The following is a description of a gene set: Mouse Gene Set: ZFP953_TARGET_GENES from publication Yevshin I, Sharipov R, Kolmykov S, Kondrakhin Y, Kolpakov F (PMID 30445619) species: Mus musculus Genes containing one or more binding sites for (Zfp953) in their promoter regions (TSS -1000,+100 bp) as identified by GTRD version 20.06 ChIP-seq harmonization., and this is the list of marker genes: Gm26795, Pnliprp1, Altre, Ahcyl1, Gm7094, Gm8883, Cylc2, Gm24665, Ube2h, Adcy10, Gm15066, Glrx5, Gm22935, Arl2bp, Vdac1, Or4c35, Gm6366, Mycbp2, Faddos (NCBI Gene Id 100038412), Eva1c, Pzp, Gm9506, AA986860, Dhx9, Rian, Gzmm, Bola3, Scpep1, Map3k5 (NCBI Gene Id 320994), BC048507, Gigyf2, Capn11, Ndufa12-ps, Gm42799, Ppp2r5c, Oscp1, Pdk1, Becn2, Mcts1, Mdk, Gm13916, Gm12340, Glra2, Snph, Acbd6, Zfp212, Gm5466, Frmpd4, Exosc2, 2210417A02Rik, Urgcp, 2900079G21Rik, Fam76a, Zp1, Fam219aos, Mphosph9, Slc22a7, Zan, Scarb1, Krtap22-2, Gm13094, Zmiz2, Rpl10-ps2, Parn, Slc7a2, H2-M2, Mir21c, Creb3l3, Kcnip4, Arfgef1, Cracr2a (calcium release activated channel regulator 2A), Ift122 (intraflagellar transport 122), Mlxip, Supt7l, Kdm3b, 1700023H06Rik, Plaa, Aldh2, Spata1, Rfx4, Zfp512b, Gm15782, Gm5255 (predicted gene 5255), Ttc39c, Ell3, Gm8213, Myo5b, Cnppd1, Tmem131, Ncmap, Gm12980, Senp3, Asah1, Mettl13, Mir103-2 (microRNA 103-2), Gm11872, Pou2f2, Mysm1, Epha10, Ccdc28a, Nicn1, Cenpe, Zeb1os1, Tbx15, Gm12803, P2rx7, Ltbp3, Gm10059, Prrc2a, Maf, Cacna2d4, Dot1l, Stag1, Speg, Chchd10, Gm11197, Luc7l3, Prdm10, Afdn, Gpkow, Stat3, Gfm1, Mcf2l, Nudt5, 4930556N13Rik, Ms4a4c, Gm14016, Manba, Mir1947, Kctd13, Usp4 (NCBI Gene Id 22258), Ncor1, Or2t43, Zbtb11, Rps13-ps6, Rtl5, Alg13, Gm25609, Cav1, Cyp4a28-ps, Pcsk6, Lgals4, Rcbtb1, Gm26343, 4930505A04Rik, Gm19705, Nt5el (5' nucleotidase, ecto-like), Rab34, Ext1, Aatf, Nrip1, Dsc1, Emx2, Gm14752, Srsf1, Rsph14, AU016765, Csn1s2b, Smagp, Rab11a, Tal1, Nr5a2, Mir6367, Rsl1d1, Unc13b, Zfand2a, A230083N12Rik, Adcy7, Gm26081, Gm11691, Tgif1, Pcdhb18, Gm13842, Rell1, Mir450-2, Dab2 (NCBI Gene Id 70555), Lrrc23, Cit, Cenpi, Kat2b, Slc11a2, Scin, Cp, Ptges3, Gm34248, C9, Nhsl2, 5830432E09Rik, Pcdh19, Lpin2, Mkrn2os, Klhl18, Or6n1, Aars1, Slc1a1 (NCBI Gene Id 319379), Phb1, Bdh2, Ipo13, Myom3 (NCBI Gene Id 433768), Hspa8, Ubr1, Rhbdd2 (rhomboid domain containing 2), Mtfr1, Shf, Mindy3, Slc34a2, Mzf1, Adck2, Mamstr, Baz1b, Abo, Prss40, Prpf38b, Gm26725, Slc6a20b, H2-M5, 5830487J09Rik (RIKEN cDNA 5830487J09 gene), Tifab, Gm6096, Rnaseh2a, Got1l1, Fbxo42, Atp5f1b, Cfp, Garin2, Irf3, Tpd52, Vac14, Tpx2, Uts2r, Atrip, Lmo3, Il17rc, Dgcr8 (NCBI Gene Id 94223), Atat1, Slitrk5, Pdlim5, Hoxa11os, Gm12339, Gm18254, Anks1, Efna3, Tulp3, Kcnj16 (NCBI Gene Id 338361), Zbtb43, D630002J18Rik, Eif4e, Sec14l5, Ptpn2, Jakmip1, Magea2, Abcb9 (NCBI Gene Id 56325), Peg12, Tbc1d23, Itgbl1, Islr, Has2os, Glis3, Myorg, Mecomos, Lhfpl6, Ermp1, Rab43, Cep85, Smok3b, Crem, Rtp3, Mir1191, Gm6872, Ing3, Dcbld2, Ddx52, 2310034O05Rik, Emc1, Scd4, Thpo, Gm25217, Kcnmb4os2, Tmem53, Cct4, Kcnu1, Fam193b, Atg14, Fanca, Ctsh, Defb42, Tnik, Zc2hc1a, Tbc1d14, Ppfia1, Srsf11, Kdm5b, Gm22581, Cst12, Nup88, Prkag1, Cars1, Gm15413, Mir6385, Rbm5, Ganc, A430072P03Rik, Alyref, Gm12125, Mir7069, Rnf115, Nipbl, Dnajb2, Mta2, Tmbim6, Setdb2, Setd1a, 4930522H14Rik, Gm20706, Teshl, Adipor2, Ncaph, Pvt1, Cnbd2, Gm42875, Zpbp2, Arhgap28, 2810432F15Rik, Smarcd3, Myh13, Slc38a8, Tbl3, Gm10729, Trpm1, Lhfpl4, Ttc27, Gm16166, Sox1, Nvl, Xab2, Iqsec1, Wsb1, Rida, Adarb1, Mir215, Gfm2, Rab3gap1, Pde4b, Clec2d, Il4, Rnf169, Oaz2-ps, Lamp2, Rfwd3, Cygb, Clk2, Agrp, Ccdc121rt2, Rps27a-ps3, Btbd19, Best2, Krtap20-2, Fndc11, Kpna7, Fbxo28, Manbal, Rgs3, Enah, Hapstr1, Garre1, 9530082P21Rik, Rpl27rt, Arpc5l, Gimap9, Gm25482, Gm14175, Zmynd12, Uba2, Eif2d, Anapc15 (NCBI Gene Id 75430), Rnf126, 4933408N05Rik, Ehd4, Babam1, Atxn2, Gm20443, Nek9, Atp7a, Gm23605, Ube2k, 8030423F21Rik, Tpk1, Pde4dip, Ankrd40, Gm28836, Phlpp2, Slc38a10, Triap1, Spata16, Tmem129, Rps27l, Best4-ps, Alg11, Bcar3, Ube2e3, Slc38a4, Mir450b, Pid1 (phosphotyrosine interaction domain containing 1), Tfr2, Cse1l, Mdn1, Cux1, Rpl14-ps1, Smim14, Gm23615, Tnfrsf1a, Adat1, Zfp653, Wdfy3, Shisa5, Gm10532, BC050972, Slc6a4, Phex, Tatdn2, Snrnp25, Gm12739, 5730435O14Rik, Nckap1 (NCBI Gene Id 96983), Rp31-ps19, Lmo7, Gm15610, Sall1, Slc44a1, Aff1, Gm6733, Gm28453 (NCBI Gene Id 69340), Dars2, Ect2, Dgkz, Smpd5, 1810053B23Rik, Jph4, Gm23723, Parp14, Hoxa11, Usp3, Gm26490, Gm6491, Or2c1, Hars2, Gm8849, Gm11637, Zfp7, Fkbp4, Hspe1, Gm29332, Dnaaf9, Tgoln1, Zcchc14, Gm4847, Inpp5k, Tnfrsf9, Ikbkg, Rbms3, Tbc1d9b, Dtx3, Adig, 4933424L21Rik, Nedd9, Irf8, Eri3, Slc25a2, Ctcf, Psmd11, Gm23347, Gm16185, Niban2, Nfe2, Ralgps1, Mfap1b, Smc4, Lbhd1, Bmal1, Il27ra, Tns1, Gm43772, Taf1c, Tnks2, Gm5874, Ifng, Dennd2a, Plppr1, Dpp4, Zbtb25, Fgfr1, Tsc22d4, 1500015A07Rik, H3f3b, Dnah2, Cope, Gc, Gm8805, Crb2, 9430015G10Rik, Nts (neurotensin), Psmd4, Bcl7b, Pf4 (NCBI Gene Id 56744), Cirbp, Xpr1, Foxp1, Oasl2, Gpr68, Phactr4, Gm23644, Psma3, Tmem202, Papola, Gm43699, Abcg3, Atosb, Sox4, Gnl3, Mrpl21, Lzts3, Spns3, Atp6v0a1, Camk1g, Uhrf1, 1500012K07Rik, Aebp2, Msantd7, 6430548M08Rik, Togaram2, Gm527, Morf4l2, Mroh1, Esrp1, Tm4sf5, 1700094J05Rik, Vmn1r193, Ubtd2, Ubxn1, 2810407A14Rik, Mb, Gm25526, Gm15901, Gipc2, Bltp2, Mtf2, Ctbp2 (C-terminal binding protein 2), Gm14534, Fgfr2, Gm24461, Myo1g, Slx1b, Pttg1ip, Slc12a5, Rbm47, Car7, Gabrr2, Slc36a3os (NCBI Gene Id 102634079), Lcn12, Trim8, Magohb, Ddx23, Spcs1, Ercc2, Treml4, Ube2d-ps, 1700016P04Rik, Map2k1, Zbtb9, Rigi, Sftpb, Rcor2, Myo10, Nek2, Atp5mj, Gm4918, Slc25a13, Plcxd2 (phosphatidylinositol-specific phospholipase C, X domain containing 2), Myo15a, Gm16276, Prex1, Toe1, Cyb5r3, Gcn1, Pitpnm2, Lpin3, Aida, Shprh, Igfbp4, Calcoco2, Tle6 (transducin-like enhancer of split 6), Trim67, Gm15895, Ifrd1, Lpcat1, Slc25a36, Stradb, Gm2800, Gm12021, Sez6, Mib2 (mindbomb E3 ubiquitin protein ligase 2), Pomgnt1, Pou2f1, Naa15, Tram1, Usp51, Pgap1 (NCBI Gene Id 75976), Sipa1, Sybu, Myo3a, Gm24204, Atp2b4, Hsp90aa1, Smg5, Gm10309, Celf1, Kdm5c, Oaz3, Rhbdl2, Plet1os, Smad7, Tfrc, Gm6209, Capn10, Gm9955, Gpr157, Rad50, Pacrg (NCBI Gene Id 69310), Mdfic2, Gm13197, Ccndbp1, Opcml, Wdr5, Coq10b, Or8k36-ps1, Mapkbp1, Slc35b1, Mov10l1, Znrf1, Gm25489, B3gat1, A830031A19Rik, Bola2, Eif2ak4, Tsg101, Wdr33, Slc38a11, Slain1, Gm9887, Usp2, Fmc1, Hdac4, Gemin2, Bex6, Sdf2, Slc24a2, Sergef, Srp72, Atp2c1, Ngb, Map4, Rps2-ps11, C630004M23Rik, Kcnv2, Gm12057, Nhlrc3, Gm12740, Nr6a1os, Ets1 (NCBI Gene Id 330916), Efhc2, Gm24257 (predicted gene, 24257), Arhgdib, Zhx3, P4ha2, Ager, Phldb2, Gm29243, Rnpep, Lrrc4c (leucine rich repeat containing 4C), 1600010M07Rik, Scn1a, Gm27811, Mttp, Pnkp, Gpr107, Rps12-ps7, Arhgef19, Hoxa3, Mcmdc2 (NCBI Gene Id 240697), Tpd52l2, Chrna10, Vcp, Shbg, Gm26207, Ralgps2, Wfs1, Lztr1, Col9a3, Gemin6, Fam193a, Tomm34, Gm7181, Spred2, Eftud2, Ifna13, Dock2, Sptb, Gal3st1, Zbtb8a, Cdr2l, Jak1, Agps, Fau-ps2, Slco1c1, Shmt1, Dhcr7, Gm22272, Fam53b, Gm12189, Prpf38a, Acyp1, Gnpat, Sntb2, Gm25369, Platr27, Elp1 (NCBI Gene Id 97146), Celf2, 1700047L14Rik, 5730480H06Rik, Gm12313 (predicted gene 12313), Gm11475, Csf1r, Sirt7, Gm43522 (predicted gene 43522), Wdr47, Tsga13, Cdh13, Ppp4r1, Gm8421, Gm37885, Mir450-1, Mettl21c, Doc2g, Ebf2, Zfp568, Rprd2, Jup, Lifr, Ppp1cb, Ramp2, Ino80, Gfi1, Grin3b, Smco4, Gm24888, Slurp2, Elp6, Cald1, Tspyl2, Ppp4r4, Selplg, Pisd-ps1, Med1, Xpnpep1, Rps6ka1 (ribosomal protein S6 kinase polypeptide 1), Nmnat3 (NCBI Gene Id 74080), Crot, Gm15197, Sun1, Gna11, Ankrd1, H2-K1, Gys2, Gm15014, Gm5532, Mamdc4, Erg, Mir3069, Recql, Nav2, Fry, Habp2, Mir1306, Plcb2, Ptpn11, Ushbp1, Sertad1, Runx2, Cenpo, Tapt1, 2010109A12Rik, Gm24400, Gm24043, Dnajc11, Gm16063, Gm6736, Zmynd11, Arhgap15, Gm24066, Gtf3c2, Rbms2, Amigo1 (NCBI Gene Id 229716), Gm17430, Myh14, Gm23123, Slc39a2, Gm7891, Fam171b, Chchd7 (NCBI Gene Id 66433), Sertad2, Pik3c2g, Gm12091, Rps6-ps3, Gm12236, Smc3, Nsun5, Tmem248, 4930532M18Rik, Spata6, Hoxa7, Gm24296, Prkcd, Gm25608, Taok2, Lalba, Tmem42, Tspan8, Pspn, Pxn, Mindy1, Pdzd9, Ighg1, Wdr12, Ly6g, Sspn, Lonp2, Sipa1l3, Myo18a, Golga5, Adam32, Gm3307, Slu7, Nadsyn1, Strn4, Cyp2b23, Sft2d1rt, Zfp661 (NCBI Gene Id 72180), Mir194-1, 0610031O16Rik, Tulp1, Psmd7, BC065397, Pdzk1ip1, Cln3, Mbtps2, Flad1 (flavin adenine dinucleotide synthetase 1), Abca16, Susd6, Rbbp6, St13, Srebf1, Prss36, Mpi, Gm5248, Fus, Axdnd1, Brix1, Pnpla7, Rad1, Gm5764, Gm4349 (predicted gene 4349), Prss54, Gm6649, Mir326, Rfx2, Papss2 (3'-phosphoadenosine 5'-phosphosulfate synthase 2), Mrpl20, 4930447C04Rik, Togaram1, Mas1, 1700003F12Rik, Fam241b, Psmd2, Surf6, Plekhg1, Gm11548, Smarcb1, Ica1l, Bace2, Gm13207, Fars2, Plekha6, Hsd3b7, Ino80dos, Gm10443, Faiml, St14, Fastkd5, Mir10b, Sp1, G6pc3, St6galnac2, Tns3, Pcmt1, Gm19261, Akr1a1, Iqce, Srpk2, Zfta, Abcf3, Smpd2, Or4d11, Ptrh2, Gm11665, Dbn1, Gm23382, Esr2, Mecom (MDS1 and EVI1 complex locus), Rhoh, Lce3c, Tmem252, Recql5, Gm13213, Hmgb1-rs16, Gm16351 (NCBI Gene Id 102632686), Ttf2, Gm5660, Ccl7, Rad54l, Gm29718, Cdh5, Sp2, Lingo4, Gm15651, Echs1, Trp53i13, Flvcr1 (feline leukemia virus subgroup C cellular receptor 1), Mir3098, Cdkn1a, Impdh1, Cd101, Thoc2l, Adgrg5, Mir3618, Ube2f, Ighv5-6, 2510002D24Rik, A630072M18Rik, Atp6v0d1, Gm25224, Gm7993, Rfx7, Elp5, Gm12333, Sardh, Atg13, Slc12a3, Ficd, Galnt1, Plekha5, Atpaf1, Exosc8, A830035A12Rik, Cenatac (centrosomal AT-AC splicing factor), B3gnt7, Uvrag, Gm14227, Snapin, Gripap1, Gm24797, Gm42161 (NCBI Gene Id 105246972), Asl, Gm23390, Sirt4, Fbrsl1 (fibrosin-like 1), Haus5 (HAUS augmin-like complex, subunit 5), Rragc, Sycp2l, 9130230L23Rik, Samsn1, Fnbp4, Gm12393, Golga2, Tmeff2, Syt8, Anxa7, Gm7108, Gm16754, Gm16342, Ncoa3, Kcnt2, Pcdhb22, Txndc9, Tle3, Pparg, Myo1c, Map3k8, Rrp7a, Slit2, Nsd2, Dhrs3, 4930591A17Rik, Psma7, Mkx, Dlk1, Was, Osbpl7, Tdrd9, Slc39a1-ps, Vapa, Bnip1, Mat2b, Mpzl2, Pi4ka, Gm6365, Nbeal2 (neurobeachin-like 2), Strada, F2, Lst1 (NCBI Gene Id 16988), Cdc42ep1, Gm14210, Gm20544, Slc22a19, 4930533L02Rik, Gm26560, D830025C05Rik, Gm15039, Nrbp1, Hspa4, 4931406C07Rik, Agap3, Gm22972, Azi2 (NCBI Gene Id 27215), Il23a, Phf20, Cpsf4, Taf1d, Ints13, Uts2, Rere, Gm25862, Esr1, Oplah, Igf1r, Myrfl, 1700022A21Rik, Scfd2, Hhip, Prrg3, Fbxl22, Akr7a5, Adgrl3, Atf7ip, Sqstm1, 1700039M15Rik, Serpinb6e, Vps35l, Tm9sf4, Zdhhc15, Ifitm10, 1700101I11Rik, Gm11454, Psmc1, Dap3, Adal, Pax6, Cfh, Spink10, Gm7097, Mettl8, Snx10, Trmt9b, Fhip2b, Orc4, Gm4342, Ehbp1, Gnai2, Gm14987, Traj1, Ctnnal1, Ergic1, Kmt5c, Plekhb1, Mfn1, Gm9599, Mir3108, Gpr84, Dpep3, Ankdd1a, Patj, Sv2b, 1700052H01Rik, Cacng8, Mvd, Sart1, Hectd4, Gm25184, Frmd4b, Tldc2, Appbp2os, Oxct1as, Oas2, Ttf1, Uap1l1, Kit, Pik3cd, Rwdd4a, Gas8, Gtdc1, C030013C21Rik, Rassf3, Khdc1c, Serpinb11, Aste1, Thrap3, Chrna9, Morrbid, Gm26019, Ncoa4, Nsf, a, Cfap74, Ces1d, Tom1l1, Carhsp1, Drg1, B130034C11Rik, Mfsd2b, Nup160, Pakap, Cracr2b, Anp32e, Terf2, Olig3, Shc1, Acat1, Dync1h1, Pdlim1 (PDZ and LIM domain 1 (elfin)), Mgat5, Park7, Pik3ap1, Mir7035, Ttc19, Polr3c, Gm13755, Gm12848, Synpo2l, Ntpcr, Suv39h1, Egfl6, Arhgap26, Gm4784 (NCBI Gene Id 213474), Hspd1, C230071H17Rik, Glipr1, Fmn1, Fat2, Tmem161a, Prim2, Inhbc, Gata3, Arih2, Mylpf, Caml, Tigd4, Rad54l2, Nadk2, Dnajc17, Paupar, Ep400, Plekhb2, Atrn, Sema4d, Cd180, Hkdc1, Farsa, Gm16519, Gm22422, Xpnpep3, Smok3a, Oser1, Gm7821, F830112A20Rik, Pik3r1, Gm23479, Irf5 (NCBI Gene Id 27056), Ubxn4, Gm10069, Gm15411, Jkamp, Ufsp2, Tet1, Rec8, Fam186b, Aqp7 (aquaporin 7), D830032E09Rik, Zwilch, Dipk1b, Lbr, Tanc2, Arrdc3, Tcp1, Pde8a, Simc1, Tanc1, Adamts1, Capn9, Adrm1b, Mettl1, Cryl1, Gm30292, Plekhs1, Btrc, Lyg1, C230066G23Rik, Gm22504, Scube3, Gm24878, Azin1, C5ar1, Arpp21, Mrpl14, Rph3a, Gm22122, Adamts8, Fxr2, Rpl21-ps9, Ift81, Plekha3, Erbb4, Rptor, Lyrm4, Gm40319, Gm12977, Mir224, Mir218-1, Fam169b, Uba52, Il2ra (NCBI Gene Id 16184), Safb2, Elk4, Gm15266, Dhx16, Mroh7, Pgap2, Babam2, Meis1, Rpa2, Gm15550, Taco1, Gm10268, Snx1, Hsd11b1, Trp53cor1, Ppip5k1, Lgi1, Gm9496, Or1p1, Gm26070, Cblc, Smg7, Pigx, Ttc3, Or1a7-ps1, Gm36536, Dhtkd1, Cib1, Sag, Herc1, Agpat2, Lrrc37, Tamm41, Srpk1 (NCBI Gene Id 20815), Cspp1, Six6, 9430024E24Rik, Cct3, Mir6405, Nudt1, Ino80d, Casp8, Kcnh8, Bcl2l12, Gm15984, Gm14111, Fkbp8, Rogdi, Tcf4, Csdc2 (cold shock domain containing C2, RNA binding), Gm23502 (NCBI Gene Id 115488440), Pdpr, Scn3a, Tpm3, Atrnl1, Gm11198, A330102I10Rik, Gm12828, Rai1, Meox1, Vgll4, Src, Gm10531, Iho1, Ccdc185, Spaca3, Ank3, Gpr35, Fbxo11, Tbx3os1, Ddx60, Gm2474, Gm12936, Ercc6, Gm25438, Zbtb1, Srrm1, Yeats2, Gamt, Bin2, Gm12571, Adamts19, Rasa3, Ndfip2, B4galt7, Rora, Zfr, Lrrtm3, Slc2a3, Pigm, Atp23, Uqcrc2, Rffl, Gm11191, Slc43a1, Il15ra, Limk2, Ern2, Gm24068, Ighd3-1, Ube2e1, Tcof1, 1700120B22Rik, Sinhcaf, Degs2, Nsa2, Atp8b3, Utp25, Zfp809, Tnks1bp1, Agap1, Mir7675, Kank3, Or4x12-ps1, Thbs3, Tekt5, 4930512H18Rik, Phox2b, Trpv2, Snf8, Igkv18-36, Gm8581, Atp8b4, Cyp2c70, Sulf1, Radx, Rcan2, Ltbp1, Zfp748, Neb (nebulin), Txndc2, Gm16261, Pcdhgc3, Hapln1, Drd1, Cdk16, Ccdc116, Ctdspl2, Top3b, Pde7b, 9330162B11Rik, Gm14095, Gm3786, Rpl9-ps4, Crb3, Pde9a, Rpl31-ps9, Fkbp7, Mxra8, Mfge8, Sbf2, Septin9, Ddx20, Rhot1 (ras homolog family member T1), Adamtsl2, Gadd45gip1, Fem1c, Cep164, Or55b4, Ext2, Rdm1, R3hdm2, Stpg3, Mrps11, Ccdc9, Cfap73, Gm7069, Inpp5f, Plin1, Lancl1, Phf24, Gm15607, Msrb3, Chd8, Gm11736, 5031434O11Rik, Ctrl, Ly6g6f, Lims1, Gm13777, Evl, Lrrc42, Il34, Eif2b3, E430021H15Rik, Timm17b, 9530003O04Rik, Atxn1l, Klhl22, Gm14901, Senp6, Rapgef4, Phf21a, Sass6 (NCBI Gene Id 72776), Serpine2, Gm24782, Gm11149, Rplp2, Cep95, Med18, Pick1, Mkln1 (muskelin 1, intracellular mediator containing kelch motifs), Ggnbp1, Gm11771, 4930507D10Rik, Cwh43, D030056L22Rik, Stra6, Nr1i3, Cfhr3, 2310016D23Rik, Cxxc1